Given this list of marker genes Kcnma1, Nppc, Irag1, Rgs2, Slc8a1, Gucy1a1, Sod1, Grk2, Pawr, Abcc8, Prkg1, Adora2b, here is a description of the gene set: species: Mus musculus Mouse Gene Set: GOBP_RELAXATION_OF_SMOOTH_MUSCLE A process in which the extent of smooth muscle contraction is reduced. Smooth muscle differs from striated muscle in the much higher actin/myosin ratio, the absence of conspicuous sarcomeres and the ability to contract to a much smaller fraction of its resting length.